Given this list of marker genes H2BC5, H2BC26, UNG (uracil DNA glycosylase), H2AC4, H2BC15, H2AB1, NEIL1, H2BC12, POT1, H2BC12L, H4C1, H2AZ2, NEIL2, TERF1, H2AC14, H2AJ, H2BC17, H2AC6, H2AX, H2BC11, TERF2, MBD4, H2AC7, H2AC20, NTHL1, ACD, H2AC18, H2BC13, H2BC9, H2BC14, SMUG1, OGG1, H2BC3, TERF2IP, TINF2, NEIL3, H2BC21, H3-4, H2BC1, TDG, H2BC4, here is a description of the gene set: Reactome Pathway: Cleavage of the damaged pyrimidine part of: Depyrimidination Damaged pyrimidines are cleaved by pyrimide-specific glycosylases. species: Homo sapiens